Given this list of marker genes PLAU, RHOD, DUSP4, MALL, LY6E, CD44, MT1H, FAM50B, ZFP36L2, PMEPA1, EGLN1, DLGAP4, PHC2, LAMP1, SLC35F6, NFKB2, HOMER3, DUSP7, NEDD9, RANGAP1, MYO9B, MBD1, FXR2, XAB2, PPIF, ARHGEF18, GLRX3, TOR4A, TM4SF1, EXT1, CCND1, CDK9, PICALM, PHLDA2, TRAF4, VASP, BIN1, MAP2K3, MT1X, SFN, TACSTD2 (NCBI Gene Id 4070), SERPINE2, SERPINH1, ACTC1, GPRC5A, RHOC, KRT17, SYDE1, EFHD2, PARVA (NCBI Gene Id 80050), PCGF2, MAD1L1, MBP, CDV3 (CDV3 homolog), SNRPF, PLEC, PGAP6, TRIO (trio Rho guanine nucleotide exchange factor), TGM2, SORBS3, MT2A (metallothionein 2A), PNO1, TNFRSF12A, DGAT1 (NCBI Gene Id 8694), DAPK3 (NCBI Gene Id 1613), GABPB1, CHST11 (NCBI Gene Id 55807), ITGA5, SERPINE1, AGRN, OSMR, BRD2, AMIGO2, HEBP2, GPAA1, B4GALT1, HMGA1, ISG20, CYB561, IL11, GAK (cyclin G associated kinase), DHPS, SH3BGRL3, BCL2L1, PPDPF, CTNNB1, SPHK1, CCND3 (NCBI Gene Id 896), CDYL, ARHGDIA, TNFRSF21, RELA, PTPRF, COL4A1, TUBB2A, SMTN, TSPAN14, ZYX, DCLK1 (NCBI Gene Id 9201), STC1, TMEM158, NUDT4, P3H2, ITGA6, PDLIM5, ATOSB, MT1F, INPP1, ARHGEF2, CAMSAP1, MTA1, PLPP3, ITPR3, PTGS1, GMDS, COL4A2, ACTN1, RNF126, MICAL2, LTBR, BRD3OS, ENC1, FST, SLC25A37, TUBB4B, RRP1, CAMTA2, ERCC1, ITGA2, SEPTIN9, FOXD1, DPAGT1, ABHD2, MTAP, NCLN, EHD1, IGFBP4, SLC19A1, TBC1D2, PDLIM7, NET1, RRBP1, HPCAL1, RRP12, PPIAP21, KYAT1, BCAR3, HMGXB3, GRAMD1B, LPCAT4, DIAPH1, EGFR, USF2, PVR, SLC1A5, ITGB5, FGFR1, HBEGF, PLAUR (NCBI Gene Id 5329), TPBG, POM121, YJU2, TNS4, SH2D2A, here is a description of the gene set: Human Gene Set: AMIT_EGF_RESPONSE_480_HELA from publication Amit I, Citri A, Shay T, Lu Y, Katz M, Zhang F, Tarcic G, Siwak D, Lahad J, Jacob-Hirsch J, Amariglio N, Vaisman N, Segal E, Rechavi G, Alon U, Mills GB, Domany E, Yarden Y (PMID 17322878) Signaling pathways invoke interplays between forward signaling and feedback to drive robust cellular response. In this study, we address the dynamics of growth factor signaling through profiling of protein phosphorylation and gene expression, demonstrating the presence of a kinetically defined cluster of delayed early genes that function to attenuate the early events of growth factor signaling. Using epidermal growth factor receptor signaling as the major model system and concentrating on regulation of transcription and mRNA stability, we demonstrate that a number of genes within the delayed early gene cluster function as feedback regulators of immediate early genes. Consistent with their role in negative regulation of cell signaling, genes within this cluster are downregulated in diverse tumor types, in correlation with clinical outcome. More generally, our study proposes a mechanistic description of the cellular response to growth factors by defining architectural motifs that underlie the function of signaling networks. Genes whose expression peaked at 480 min after stimulation of HeLa cells with EGF. studied in species Homo sapiens